Given this list of marker genes CCR8, ENTPD1, NR4A3, ITGB8, CD96, CSF1, BID, HAVCR2 (NCBI Gene Id 84868), HSP90B1, XBP1, POLE, CLSTN1, PTGER4, TRIM62, SNX9, KCNA3, NT5E, TANC2, FAM169BP, GRIK5, SPRY1, CAPN2, KCNQ5, TANK, VAV2, RALGPS1, SH3RF1, UBASH3B, GATA1, CHEK1, ST8SIA4, TNFRSF18, MRE11, SMYD2, IGF2R, NRP1, NABP1, NFIL3, PHC3, PPM1L, B4GALNT4, DNAI4, WLS, ENDOD1 (endonuclease domain containing 1), SLC22A5, MAF, LTA4H, CRMP1, VIM, HOMER1, AHCYL2 (NCBI Gene Id 23382), NR4A1, PARP2, CERK, HDAC9, CLDND1, CYTH3 (cytohesin 3), PIP5K1B (NCBI Gene Id 8395), DUSP4, NFKB1 (nuclear factor kappa B subunit 1), TGFBR1, PTPRS, STIM2, SCAMP1, ARHGAP18, PRKCA, ENO3, SOCS5, P4HA1, SLAMF1, DST, SLC12A2, CTLA4 (NCBI Gene Id 3411), REPS1 (RALBP1 associated Eps domain containing 1), CDCA7, RGS9, ACSBG1, MCTP1, SH2B1, PLXNC1, ETV5, SWAP70, OSBPL3, TTN, CTSZ, BMP7, IRAK2, SLC1A5, PLAGL1, PPP1R14B, MAP3K8, CAMK2D (NCBI Gene Id 817), ERCC6L, LXN, MED7, RNF43, FOXN3, SKIL, SSH1, NEK7, KLF10, SERINC5, P2RX7, IL10RA, PHTF2, PEAR1, CHSY1, DNAJB14, SLC25A13, STING1, RPS6KC1, INPP5D, CDK6 (NCBI Gene Id 1021), CTSW, WDR82, ARL6IP1, GPR15, PNP, NHLRC2, PRDM5, TERT, PLCL1, CD79B, TNIP1, PAQR3, KCNK6, CD81, TNFRSF1B, YPEL2, SMC4, PLP2, SNORD82, CD86, B4GALNT2, MCUB, CYTH4, E2F2, MKI67, CD200, KYAT3, LAMC1, RYK, ASXL1, SAMSN1, NSMF, MICAL3, NRN1, ITIH5, NEB, PTPN13, MXD4, PCGF2, TWSG1, RCN1, TNFRSF4, BANK1, DDB1, EIF4H, TGFB1, NEFH, FBXW8, TMEM64, SNX2, DPP4, RBM45, INPP4A, TNFSF10 (NCBI Gene Id 8743), PTGER2, CAMKK1, NRARP, CDK1, TBC1D4, F2R, ABCA2, RUNDC3A, CCR4, POLM, LIMK1, VWA5A, here is a description of the gene set: Genes down-regulated in pro-B cells versus RAG2 knockout NK cells. studied in species Homo sapiens Human Gene Set: GSE37301_PRO_BCELL_VS_RAG2_KO_NK_CELL_DN from publication Ramirez K, Chandler KJ, Spaulding C, Zandi S, Sigvardsson M, Graves BJ, Kee BL (PMID 22608498) Expression profiling of Rag2-deficient Ets1++ and Rag2-deficient Ets1-- mature NK cells and WT bone marrow progenitors, WT T cells, and WT Pro B cells